The following is a description of a gene set: Any process that modulates the frequency, rate or extent of growth of an organ of an organism. species: Mus musculus Mouse Gene Set: GOBP_REGULATION_OF_ORGAN_GROWTH, and this is the list of marker genes: Pin1 (peptidyl-prolyl cis/trans isomerase, NIMA-interacting 1), Trp73, Hamp2 (hepcidin antimicrobial peptide 2), Smo, Slc6a4, Col14a1, Gsk3a, Cited2, Ccn4, Sirt1, Erbb4, Gata6, Bmp10, Mir133a-2, Jarid2, Mapk14, Tbx5, Hey2 (NCBI Gene Id 30802), Zfp418, Cav3, Ahr, Cga, Nkx2-5, Zfpm2, Rgs2, Wwc2, Slc25a4, Pim1, Wnt2, Foxp1, Lats1, Adrb1, Fxn, Ccnd2, Ptk2, Cacna2d2, Tbx20, Il7, Tgfbr3, Mir1a-2, Gli1, Bmpr1a, Mapk11, Cxadr, Stk4, Agt, Yy1, Fgf8, Ybx3, Nog, Rbp4, Dyrk1a, Nrg1, Mir208a, G6pdx, Bcl2l11, Hamp, Dusp6, Wt1, Rbpj, Ppara, Nr3c1, Men1, Foxc1, Foxc2 (forkhead box C2), Prox1, Rag2, Tcf7l2, Myh6, Ncam1, Vgll4, Lats2, Mtor, Ctdp1, Pak1 (NCBI Gene Id 18482), Serp1, Fgf20, Wwc1, Acacb, Pin1rt1, Mapk1, Stk3, Pi16, Mir133a-1, Ddx39b, Ep300, Fgfr2, Tbx2, Hlx, Fgfr1, Trip10, Pten, Gata4, Cacna1c, Notch1, Igf1, Rbm10, Dspp, G6pd2 (NCBI Gene Id 14382), Yap1, Tgfbr2, Fgf9, Arx, Cdk1, Sash3, Ccnb1, Igf2, Hdac2, Fgf2, Gja1, Flvcr1, Sav1, Mef2c, Edn1, Fdps, Apc, Tgfbr1, Parp2, Mael, Rgs4, Ankrd26, Akt1, Tomm70a, Kcnk2, Tbx1, Akap6